The following is a description of a gene set: Any deviation from the normal concentration of a long-chain fatty acid in the blood circulation. species: Homo sapiens Abnormal circulating long-chain fatty-acid concentration Human Gene Set: HP_ABNORMAL_CIRCULATING_LONG_CHAIN_FATTY_ACID_CONCENTRATION, and this is the list of marker genes: PEX12, SCP2, PEX19, PHYH, AMACR, PEX7, PEX3, ABCD1, PEX16, PEX10, PEX14, PEX1, PEX26, PEX5, PEX11B, PEX6, CPT2, PEX13, PEX2